The following is a description of a gene set: Human Gene Set: chr3q21 species: Homo sapiens, and this is the list of marker genes: CIDECP2, PARP9, CFAP92, SF3A2P1, SEC61A1, OR7E97P, OR7E29P, FAM86JP, MYLKP2, ENSG00000207002, RAB7A, SLC49A4, PARP15, RPL7P15, LINC02035, SEMA5B, RNU6-823P, ENSG00000304375, EFCAB12, RNU6-143P (NCBI Gene Id 106479629), HMCES, MBD4, METTL5P2, WDR5B, MGLL, HACD2, HNRNPA1P23, TMED10P2, C3orf22, POU5F1P6, FAM162A, ACAD9-DT, ENSG00000298776, RPS26P22, ABTB1, ADCY5, MARK2P6, RUVBL1, DUTP1, RPN1, ENSG00000279328, OSBPL11, RPS3AP14, RN7SL698P, MYLK, DNAJB6P7, DNAJB8-AS1, ENO1P3, NUP210P3, EIF4BP8, ZXDC, RPS24P9, MIR548I1, ENSG00000248607, MIR6083, TXNRD3, ALDH1L1-AS1, ROPN1B, RNU6-232P, SNX4, FTH1P4, HEG1, KBTBD12, PODXL2, H1-10, CSTA, MARK2P3, ENSG00000250934, ROPN1, ACAD9, KPNA1, FBRSL1P1, GP9, CFAP100, ENPP7P4, OR7E130P, H1-10-AS1, KLF15, SNRPCP11, OR7E93P, ENSG00000207130, MUC13, OR7E53P, GATA2-AS1, EEFSEC, RPL32P3, MIR6826, TPRA1, SNORA7B, LINC02034, MIR5092, LINC01471 (NCBI Gene Id 101927149), CNBP, UMPS, PRR23E, MIR544B, IFT122 (NCBI Gene Id 55764), RUVBL1-AS1, ALG1L1P, GATA2 (NCBI Gene Id 84724), ENSG00000288022, PRR23E2P, PARP14, CCDC14, RNU1-30P, ISY1, UROC1, KALRN, ZNF148, COPG1, MYLK-AS1, ITGB5, LINC02016, LINC01472, MIR7976, EFCC1, MCM2, DTX3L, ENSG00000287232, ENSG00000289469, CFAP100-DT, VPS51P6, MIR5002, SLC12A8, IFT122P2, CHST13, PDIA5, ITGB5-AS1, HSPBAP1, MIR6825, CHCHD6, MARK2P17, RNU6-1047P, YTHDF3P1, MARK2P19, RPS27P12, SEC22A, ISY1-RAB43, RNA5SP138, JMJD4P1, PLXNA1, RNA5SP139, RPS15AP16, NUP210P1, RCC2P4, RNA5SP137, LINC02614, RNU6-230P, SLC41A3, RNU2-37P, MIX23, ENSG00000302326, ALDH1L1-AS2, RAB43, MARK3P3, ALDH1L1, DNAJB8 (DnaJ heat shock protein family (Hsp40) member B8), MARK2P8, LINC01565, PRR20G, MIR7110, WDR5B-DT